The following is a description of a gene set: Expressive aphasia Impairment of expressive language and relative preservation of receptive language abilities. That is, the patient understands language (speech, writing) but cannot express it. studied in species Homo sapiens Human Gene Set: HP_EXPRESSIVE_APHASIA, and this is the list of marker genes: NPRL3, CHMP2B, FA2H, NPRL2, GJB1, TREM2, TMEM106B, MAPT, GRN, VCP, DEPDC5, PSEN1